Given this list of marker genes FIBCD1, FNDC7, UBE2K (NCBI Gene Id 84819), DNAJC18, UBE2G1, PEBP4, WDR91, GPR22, CHI3L1, FAM120C (NCBI Gene Id 54954), KIAA0825, GTF3C6, YBEY, COL25A1, PRX, NARF, SLFNL1, CCDC183, HDHD2, LDHD, ESPN, AICDA, IQGAP1, CPED1, CCDC66, DAPL1, KLF12, INO80B, NKX2-1, SLC39A12 (NCBI Gene Id 221074), CRELD2, TEX14, ANO1, HAVCR1, DNAAF6, FBXW4, PRRX2, ERGIC2, LAD1, PPFIA3, GPR6, MYO9A, C3orf80, VSTM5, DSC2, OIT3, BSPRY, ST8SIA6, ALS2, PEA15, EPHX1, HINFP, STXBP3, SOCS7 (NCBI Gene Id 30837), FAP, ADAMTSL5, BMP5, CPXM2, SCUBE3, AP1S2, COL26A1, ARL4A, MBL2, PRDM15, PRCC, PLXNA3, VPREB3, ST3GAL5, ENDOD1, EFS, NKX6-1, NAGS, LTBP1, NPR2, GAS2L3, SLC9A6 (solute carrier family 9 member A6), PLD1, PRR13, ARHGAP24, OR51E1, CYP1A2, AKAP6, TRMT10B, CDC25B, SH3BP4, GSDMA, TMEM234, PARD6A, AXIN2, CD79A, PYGO1, HOXD4, DMRT3, BCL3, SPECC1, LRRC34, AQR, NETO2, RAD17, MGP, PARVA (NCBI Gene Id 80050), SBSPON, TEN1, TRIM54, ANKRD55 (NCBI Gene Id 79722), SEPHS1, B3GALT2, UGT2B15, RTP3, SIX5, HMGCS1 (3-hydroxy-3-methylglutaryl-CoA synthase 1), IZUMO1, NCOA4, MALSU1, COQ4, CD109, GLRA2, SDC2, MED6 (NCBI Gene Id 10001), LCMT1, CCL25, ATOH8, CDK20, TUBA8, HACD2, DDAH1, H1-8, MCTP1, CACNG8, ADAM23, GRIA2, PSMB9, YRDC, FAM241A, ARTN, TAF2, SPIN1, RPAP2, PIGX, FNDC8, SPAG17, C9orf72, YPEL2, MANF, BPIFC (NCBI Gene Id 254240), MCEE, KRT80, SH3BGRL3, SAMD7, SLC16A12, STN1, LSAMP, CRIPT, CPN1 (NCBI Gene Id 1369), SOX18, SCN1A, SNX18, ATPSCKMT, TPCN1, CHST11, LHX1, C1orf185, SLC4A1AP, PSMB4, CREB3L2, CSTF2 (NCBI Gene Id 1478), EHMT1, PTPRR, STEAP4, VPS26A, TMLHE, SFMBT2, ZC3H3, DAGLA, WDR3, GOLGA3, CST3, NALCN, P4HA1, ELOC, ANKHD1, FRA10AC1, CUX2, TNFRSF12A, LDLR, KIFAP3, RASGRF1, NAT14, SMR3A, PCBD2, FSTL1, CRACD, CYP26A1, ZNF706, LACTB, AEBP1, ACAD8, POLR2C, NDRG3 (NCBI Gene Id 64401), ANGPT4, here is a description of the gene set: Genes up-regulated in lymph node B lymphocytes: influenza infected versus interferon beta stimulation. Influenza virus infection-induced gene expression changes of regional B cells are mediated at least in part through type I Interferon: Our objective is to determine whether the influenza virus-infection induced gene expression changes in regional lymph node B cells are facilitated at least in part through type I interferon. Our specific aim is to compare the gene expression profile of highly FACS-purified B cells in the regional lymph nodes of wildtype and IFNR-/- mice prior to and 48h following infection with influenza virus infection and to contrast this expression profile with that of FACS-purified wildtype B cells activated in vitro with IFN-beta +/- anti-CD86 for 12h. from publication Chang WL, Coro ES, Rau FC, Xiao Y, Erle DJ, Baumgarth N (PMID 17237394) Human Gene Set: GSE3203_INFLUENZA_INF_VS_IFNB_TREATED_LN_BCELL_UP studied in species Homo sapiens